Given this list of marker genes Gng8, F2rl2, Gnb2, Gna14, Gng12, Gng4, F2r, Gng10 (NCBI Gene Id 14700), Gna11, F2rl3, Gna13, Gna12, Gnb5, F2, Gng11, Gnb1, Src, Arrb1, Gna15 (guanine nucleotide binding protein, alpha 15), Gng7, Gng5, Mapk3, Gnb3, Gnb4, Gngt1, Gng13 (guanine nucleotide binding protein (G protein), gamma 13), Gng2, Gng3, Mapk1, Gnaq, Gngt2, Arrb2, here is a description of the gene set: species: Mus musculus Mouse Gene Set: REACTOME_THROMBIN_SIGNALLING_THROUGH_PROTEINASE_ACTIVATED_RECEPTORS_PARS Thrombin signalling through proteinase activated receptors (PARs)